Given this list of marker genes EDA, SUMO1, WNT10B, FGFR1, EDARADD, LRP6, IRF6, MSX1, WNT10A, TGFA, AXIN2, FGF3, PAX9, here is a description of the gene set: Agenesis of premolar tooth. Human Gene Set: HP_AGENESIS_OF_PREMOLAR Agenesis of premolar studied in species Homo sapiens